Given this list of marker genes ATG9A (NCBI Gene Id 79065), ATG4C, ATG9B, ULK3, WDR45B, ATG4A, WIPI2, ULK1, ATG7, WDR45, ATG4B, ATG4D, RB1CC1, SNX30, WIPI1, ULK2, ATG13, ATG2A, ATG12, ATG3, SNX7, ATG2B, ATG5, here is a description of the gene set: A form of autophagy, by which damaged or non-essential parts of the nucleus, or even an entire nucleus is degraded. Human Gene Set: GOBP_NUCLEOPHAGY studied in species Homo sapiens